Given this list of marker genes ZFPM2, LUC7L, HOXB4, LYPD1, LRRC39, FST, NCAN, SMARCA2, H2BC1, RALY, CUL3, ATP2A3, MYH3, EPHA7, C10orf71, LSMEM2, MYOZ2, MGST3, CYP26B1, SOX5, TNNI2, PLAAT1, TCEAL7, CRTAP, ZBTB18, PLAGL2, ARHGEF38, CUX1, CELF4, ADCY2, LRRTM4, PTCHD4, RIPOR1, TRMT10A, GPC4, CA7, SMYD1, SLCO3A1 (solute carrier organic anion transporter family member 3A1), SLAMF1, DKK2, RNF145, SCAI, PYY2, MOSMO, ADGRB3, TRAK2, ACTC1 (actin alpha cardiac muscle 1), ZNF143, DTNB, BNIP3, ENO3, GCK, CLDN14, CPEB4, FBXO40, STAG2, PAK6, SLC26A9, S1PR1, TSPEAR, CFL2, LCP1, USP2, ITSN1, TYRO3 (TYRO3 protein tyrosine kinase), FITM1, LRRC20, NDP, EXTL1, VEZF1, IRS1, AKIRIN1, MYL2, KPNA3, SHANK1, DMD, KLHL41, NR4A1, SIPA1L1, CYP2E1, RGS3, PAX3, CLCN1, THBS2, TTYH2, PTCH1, HCFC1R1, FGF12, TRPS1, PDLIM1, HAPLN1, ALPK2, TWIST1, SMIM8, TPP2, THOC6, TNNC1, ZNF385B, COL8A1, TSC22D1, RASGRF1, ESR1, STRADB, MUSK, CAV3, HOXC4, CDC42EP3 (NCBI Gene Id 10602), ST6GALNAC5 (ST6 N-acetylgalactosaminide alpha-2,6-sialyltransferase 5), NRXN3, PCDH11X, ELMO1, CASQ2, CARTPT, TCEA3, ASB16, PYY, POU4F2 (NCBI Gene Id 7894), NFAT5, ADCYAP1, FOXP1, MID1IP1, STOML2, CAPN3, ADAM23, NEXN-AS1, ITGA7, SMPX, POU4F1, INPP4A, CSRP3, CACNA2D3, H2AC1, LIF, NR2F1, ART5, PPP1R3D, KCNN1, CCDC140, KLHL40, SLC8A3, DLG2, ARAP2 (ArfGAP with RhoGAP domain, ankyrin repeat and PH domain 2), MEF2C, TNNC2, ARMCX6, EEF1A2, RTL9, ATF3, HOXD4, HAS2, TNNI3K, FILIP1, MAP2K5, WFDC1, ZHX2, CLRN1, SIK3, PPP2R3A, KLF14, PDGFRA, ACTA1, SLC9A5 (NCBI Gene Id 6553), DNAJA4, PRKAG1, MAB21L2, RASGRP3, RAB2A, ELAVL4, ATP1B2, ARHGAP36 (Rho GTPase activating protein 36), MBNL2, TRDN, PTPN1, PCDH11Y, LINC01597, PMEPA1, NDRG2, CNMD, ARHGEF15, KCNQ5 (NCBI Gene Id 56479), MRPS23, RETREG1, ARR3, SLC32A1, ADAM11 (ADAM metallopeptidase domain 11), MYL3, ARHGAP26, WBP4, MEOX2, ARK2N, HJV, SCML1, SLC44A1, CASQ1, HAO1, RBMS3, RAP2C, STAC, DLX5 (distal-less homeobox 5), EHD1, FBXW11, EYA1, PRMT3, PANK1, SLC26A6, TIMP2, SH3GLB2, CNTN1, BZW2, AMPD1, CTNND2, TOB2, MIEF2, ZRSR2, ANKMY2, GPR153 (NCBI Gene Id 387509), ESAM, ARHGAP32, GRIN2B, HDAC9 (histone deacetylase 9), ZNF362, CLDN23, RTBDN, RASGEF1B, PLEKHA6, ZFAND5, PCDH9, GAL3ST3, PTPRO, KTN1, VSIG1, WSB2, TSPAN13, SV2A, TMEM71, PRDM1, DIRAS1, S100A4, PIK3R3 (NCBI Gene Id 8503), TP63, ATXN1 (ataxin 1), CKM, DGKI, B3GLCT, SSH3, NEDD4, FAM117A, LZTS2, ITGB3BP, TNFRSF17, here is a description of the gene set: Genes having at least one occurrence of the motif RNKCTATTTWTAGMWN in the regions spanning 4 kb centered on their transcription starting sites. This matches the MEF2A transcription factor binding site V$RSRFC4_01 (v7.4 TRANSFAC). Human Gene Set: RSRFC4_01 species: Homo sapiens